The following is a description of a gene set: Mouse Gene Set: GOBP_ACTIVATION_OF_NF_KAPPAB_INDUCING_KINASE_ACTIVITY studied in species Mus musculus The stimulation of the activity of NF-kappaB-inducing kinase through phosphorylation at specific residues., and this is the list of marker genes: Zfp91, Chi3l1, Card10, Tlr1, Cops8, Tlr4